The following is a description of a gene set: species: Mus musculus RUNX3 regulates NOTCH signaling Mouse Gene Set: REACTOME_RUNX3_REGULATES_NOTCH_SIGNALING, and this is the list of marker genes: Mamld1, Maml3, Kat2a, Maml2, Notch1, Rbpj, Runx3, Maml1, Ep300, Kat2b